Given this list of marker genes H6PD, BMP2, BMP5, LHCGR, WNT4 (Wnt family member 4), PDE8B, BMP6, REST, CLCN2, NR3C1, DGKQ, NR5A2, POR, ATP1A1, DKK3, DAB2, here is a description of the gene set: Human Gene Set: GOBP_REGULATION_OF_STEROID_HORMONE_BIOSYNTHETIC_PROCESS species: Homo sapiens Any process that modulates the frequency, rate or extent of the chemical reactions and pathways resulting in the formation of steroid hormones,compounds with a 1, 2, cyclopentanoperhydrophenanthrene nucleus that act as hormones.